The following is a description of a gene set: studied in species Mus musculus Mouse Gene Set: GOBP_SKELETAL_MUSCLE_ATROPHY A process, occurring in skeletal muscle, that is characterized by a decrease in protein content, fiber diameter, force production and fatigue resistance in response to different conditions such as starvation, aging and disuse., and this is the list of marker genes: Cflar, Mstn, Actn3, Rps6kb1, Asb2